The following is a description of a gene set: Human Gene Set: MIR4688 Genes predicted to be targets of miRBase v22 microRNA hsa-miR-4688 in miRDB v6.0 with MirTarget v4 prediction scores > 80 (high confidence targets). from publication Chen Y, Wang X (PMID 31504780) studied in species Homo sapiens, and this is the list of marker genes: RHBDD1 (NCBI Gene Id 84236), GYPB (NCBI Gene Id 2994), CDC42EP1, FBRS, CHIA, AFF4, TFB1M, TMEM260, GSTT2B, PCDH9, CHD3, ZSWIM5, DPY19L1, ZBTB47, SNW1, SOX10, MLIP, PTPN1, TMEM132B, DGAT2, TULP3 (NCBI Gene Id 7289), PPARD, SLC33A1, EEIG1, FUT8, SPRY2, SMUG1, HBP1 (HMG-box transcription factor 1), CDK19, TANC2, UBE2M, NEGR1, SINHCAF, PLA2G6, GTPBP1, PLCB1, MITF, CPEB3, CHST5, CNOT6L, ARPC4, POU2F2, ISLR, CAMK2A, RERG, SUFU, DGAT1